The following is a description of a gene set: species: Mus musculus Mouse Gene Set: chr11A2, and this is the list of marker genes: Cnrip1, Ppp3r1, Sec61g, Gm12007, Egfr, 4930554G24Rik, Gm12005, Eldr, Pno1, Gm12664, Gm12010, Gm12663, 1700046C09Rik, Egfros, Gm12009, Gm12014, Gm12008, Gm12013, Plek, Dnaaf10, Vstm2a, Gm23721, Akt2-ps, Gm25490, Gm12012, Pom121l12, Gm12011, Fbxo48